The following is a description of a gene set: from publication Menon R, Otto EA, Kokoruda A, Zhou J, Zhang Z, Yoon E, Chen YC, Troyanskaya O, Spence JR, Kretzler M, Cebrián C (PMID 30166318) studied in species Homo sapiens Human Gene Set: MENON_FETAL_KIDNEY_4_PODOCYTES, and this is the list of marker genes: PSAP, YIPF4, CD2AP, SEPTIN11, GOLGB1, MALAT1, HSPA5, MYL9, TJP1, SPINT2, NES, TCEAL3, S100A6, TAX1BP1, DSC2 (NCBI Gene Id 1824), CLDN5, PLCE1, TSPAN3, DDN, ADD3, PTBP3, AIF1L, MAGI2-AS3, ARMCX3, TPM1, RETREG1, ITIH5, WT1, ROBO2, KMT2E, COL9A1, ARHGEF12, PCBP1, CD59, H3-3B, PRDX6, CCNL2, ANKRD12, CRIM1, ANXA2P2 (annexin A2 pseudogene 2), BAZ2B, STT3B (NCBI Gene Id 201595), BBX, MYL6, BRD2, CXCL12 (C-X-C motif chemokine ligand 12), ARF1, TNNI1, PARD3B, ST3GAL6, THSD7A, ADAMTS9, TMSB4XP8, AIF1, DSTN, SEC62 (NCBI Gene Id 7095), NFE2L1, TTC14, RAB2A, MAGI2, PLOD2, SARAF, SPOCK2, CGNL1, DDX17, PLA2R1, PHIP (pleckstrin homology domain interacting protein), HMGN3, ZFP36L2, KTN1, SEPTIN2, SELENOP, PTMS, MYH9, TPPP3, PALS1, CD81, HSP90B1, ANXA5, FOXC1, ANKRD11, DST, TMED9, PDIA3, ITGB1, CMYA5, WASF2, ARMH4, SERINC1, CD151, VEGFA, CPXM1, MPHOSPH8, TBCB, COL4A4, DYNC2I1, CHD3, GADD45A, HIPK2, UACA, BNIP3L, BCAM, ARHGAP29, ENPEP, NPHS2, PCMTD2, SYNPO, SOST, CD63, KMT2A, APLP2, PRMT2, MTDH (NCBI Gene Id 92140), LRRFIP1, TMSB4X, MIR503HG, MAFB, RBMS1, LEPROT, GOLIM4, GINM1, PTH1R, TXNIP, NEAT1, CIRBP, CANX, TRIB2 (NCBI Gene Id 28951), RFC1 (NCBI Gene Id 5981), PHACTR4, MXRA8, EFNB2, SEMA3B, SRGAP1, DACH1 (NCBI Gene Id 1602), MAN1A2, TERF2IP, NTRK2, PALLD, NPNT, RPL36AL, TCF25, PON2, PRRC2C, RNF145, UBE2G2, TGFBR3, PODXL, PUF60, CHD4, CAST, CCN2, TCEAL9, RASSF8, NPHS1, WT1-AS, SPATS2L, TMEM150C, ALCAM, CALR, NDUFB2, PTPRO, CALM2, NORAD, FNDC3B, CLIC5, PTPN14, TYRO3, CALD1, HTRA1, TCF21, EVL, SLK, EZR, SPARC, NTNG1, PTPRD, MYL12B, PPP1R9A, ACTN4, TSC22D3, EMC10, DYNLRB1, RAD50, BST2, PLTP, IQGAP2, TNNT2, MME, EIF3M, FKBP2, AHNAK, CDKN1C, C4orf3, NEBL (NCBI Gene Id 51739), GABARAPL2, BMP7, SDC2, ITM2B, ANXA2, VIM, LUC7L3, CITED2, RDX, COL18A1, SRRM2, SULF1